Given this list of marker genes ANKS1A, AQP1, EFNA4, CRK, ANKS1B, EFNA3, EFNA5, APP, EFNB3, EFNA1, CHN1, PIK3CG, PTPN1, SIPA1L1 (signal induced proliferation associated 1 like 1), GRB2, EFNB2, EFNB1, EPHA7, EPHA4, FYN, NGEF, SRC, LYN, SHC1, ABL1, NCK1, EFNA2, CBL (Cbl proto-oncogene), here is a description of the gene set: Binding to an ephrin receptor. Human Gene Set: GOMF_EPHRIN_RECEPTOR_BINDING species: Homo sapiens